The following is a description of a gene set: Mouse Gene Set: GOBP_ALDITOL_BIOSYNTHETIC_PROCESS The chemical reactions and pathways resulting in the formation of alditols, any polyhydric alcohol derived from the acyclic form of a monosaccharide by reduction of its aldehyde or keto group to an alcoholic group. studied in species Mus musculus, and this is the list of marker genes: Got1, Pgp, Lep, Pck2, Akr1b1, Pck1